Given this list of marker genes RPP40, CDYL-AS1, ANKRD18FP, LY86-AS1, EXOC2, RPS25P7, LINC02525, TUBB2B, LINC01394, GMDS-DT, HNRNPA1P37, PXDC1, HTATSF1P2, FOXF2, RNA5SP202 (NCBI Gene Id 100873463), ENSG00000270174, LINC01011 (NCBI Gene Id 401232), FAM136BP, GLRX3P2, HMGN2P28, PSMG4 (proteasome assembly chaperone 4), GMDS, HUS1B, BTF3P7, FOXC1, LYRM4-AS1, SERPINB9, ENSG00000305114, ENSG00000231811, OR4F1P, RPS18P8, FAM217A, FOXCUT, SLC22A23, WRNIP1, TUBB2A, SERPINB1, TUBB2BP1, LINC02521, MIR5683, SERPINB8P1, MIR6720, ENSG00000272279, DUSP22, SERPINB9P1, TFB2MP1, ENSG00000228793, ECI2-DT, ENSG00000228365, LY86, FOXQ1, NQO2-AS1, IRF4, SNAPC5P1, RPL34P16, RN7SL352P, RNA5SP201, MIR4645, SEPTIN14P6, CRIPTOP4, RN7SL221P, NAA40P1, TOMM5P1, ELF2P2, ENSG00000226281, FOXF2-DT (FOXF2 divergent transcript), ECI2, LINC03066, LINC02533, MYLK4, LINC01622 (long intergenic non-protein coding RNA 1622), BPHL, KU-MEL-3, RN7SL554P, PRP4K, NQO2, LINC01600, LYRM4, RIPK1, ENSG00000301233, MARK2P18, TEX56P, WBP1LP12, CDYL, F13A1, MIR7853, LIRIL2R, PPP1R3G, NRN1, MIR3691, FARS2, SERPINB6, PSMC1P11, FAM50B, CNN3P1, FARS2-AS1, PKMP5, here is a description of the gene set: Human Gene Set: chr6p25 species: Homo sapiens